The following is a description of a gene set: from publication Ng SY, Yoshida T, Zhang J, Georgopoulos K (PMID 19345118) Genes up-regulated in hematopoietic stem cells versus pro-B lymphocytes. Human Gene Set: GSE15330_HSC_VS_PRO_BCELL_UP Regulation of lineage potential and transcriptional priming by Ikaros. New insight is provided into a bivalent regulation of lineage priming in the HSC and its lympho-myeloid restricted progeny the LMPP by the lymphoid lineage-determining factor Ikaros Whereas Ikaros is responsible for the activation of a cascade of lymphoid expression programs and for the establishment of lymphoid potential from the HSC to the LMPP it is also responsible for the repression of stem cell and erythroid genetic programs that are incompatible with further lineage restrictions emanating from the LMPP species: Homo sapiens, and this is the list of marker genes: CYBA (NCBI Gene Id 1535), PPP1R7, CEP15, LAG3, SELPLG, RTTN, PPP1CC, TRIM37, EBPL, IPP, ZNF410, ADCY7, FLT3LG, IPO9, FAM3C, ABHD17A, TCF7, IFT74, PFKFB1, NSG2, SLC25A42, KATNBL1, RASAL3, KLHL7, PC, IGSF9, PHKA2, BSCL2, RLIG1, TOPBP1, PRADC1, NSMCE4A, FYB1, NAP1L1, LZTR1, TRAPPC13, CD247, BOLA1, NEK7, RCBTB1, VDAC1, APOOL, FAM149B1, TMEM128, FTSJ1, CUEDC2, KLF6, CCN4, ZNF362, SRPK2, RPRD1B, MAP3K4, ACYP2, FABP5, NUDT14, CRAMP1, SLC39A1, DNAJC3, PITPNC1, HACL1, NDUFA8, HUS1, PSMD9, CLTB, SEC24D, GIMAP4, MAP4, DHRS3 (NCBI Gene Id 9249), RAB34, SMIM14, HDAC6, CAB39L, CYTH1, PRKCB, TUBG1, RDM1, ZDHHC12, RFX1, BRD3, PFN1, HCLS1, SH3YL1, NDUFA9, MCM2, CPTP, COMT, TSEN15, STK26, EML3, RCSD1, ZBTB8A, ACTB, CD48, COX6B1, MBNL1, LEF1, GATD3, AGPAT3, C1QTNF12, TMEM158, GPR89B, TBC1D1, SSRP1, SLC4A8, TM4SF5, HMGCS1, FGFR1OP2, STK11IP, IFT122, HERC1, EPSTI1, GLRX, SGCB, EMILIN1, DEK, PATZ1, CTSE, RBMX2, FOXRED1, ALDH9A1, CNOT9, BRDT, MFAP2, NUCB1, PEA15, GPSM3, AAK1, RNGTT, ABCA2, SCARB1, MRPL14, GLE1, EFCAB2, SMARCC1, SEPTIN8, ELP4, UNC119, CCR6, POLE3, LIAS, SNCAIP, DDRGK1, FAAH, PNN, GLOD4, RABGAP1L, ESYT1, ST6GAL1, ABHD8, PDE7A, SPTSSA, NTPCR, NUP88, EEF1B2, GRAMD2B, STK3, FAM76A, ZMYM1, TRDMT1, CMTR1, CDKN2AIPNL, CHCHD7, STARD3NL, RPA3, MTMR4, MRM2, CRYBG1, OSTF1, ASB3, STX7, ZNF207, GPAA1, TUBD1, TM9SF1, ITGB7, IFT27, FUNDC1, COX6A1, KLF3, NCAPH2, GLUD1, FAF1, RNH1, PGM2, EIF4ENIF1, SREBF1, TXK, MBNL3, TOMM40L, TLCD2, SUMF1, WASHC3, HINT2, CALCRL, FAM174A, NABP2, FANCG, RNF187, ELAC1, PEX7